The following is a description of a gene set: Human Gene Set: GOBP_POSITIVE_REGULATION_OF_EARLY_ENDOSOME_TO_LATE_ENDOSOME_TRANSPORT species: Homo sapiens Any process that activates or increases the frequency, rate or extent of early endosome to late endosome transport., and this is the list of marker genes: VPS11, RAB21, MTMR2, NF2, MSN, RDX, DAB2, EZR, PTPN23